Given this list of marker genes RBBP7, FYN, CTBP2, PSMD6, TWIST2, PSMA4, OST4, RBBP4, TMEM258, ARHGAP32, MOGS, MIR9-1, SUZ12, SNAI1, TCF3, PSMA6, PSMD2, ACTC1, KMT5A, H3-3A, SNAI2, ZBTB33, SP1, FOXA2, HDAC1, SIRT1, SMARCA4, ACTB, PSMD13, SPCS3, TLE1, H2AC20, H2BC1, MAPK1, OSTC, RB1, PSMB4, RPS27A (NCBI Gene Id 6233), PSMC2, PSMB1, HDAC2, MYCN, PSMB5, CBLL1, ACTA1, GANAB, PSMA7, EPS15, H2AC6 (H2A clustered histone 6), TGIF2, PSMD8, PSMD14, ADRM1, POMT1, MIR9-2, ACTA2, SEM1, H2BC3, PCSK6, PSMA2, H2AC4, SPCS1, CTNNB1, ZNF217, FURIN, H4C1, PSMD7, TFAP2A, CTSL, H2BC12L, H2AC18 (NCBI Gene Id 8337), UBB, SEC11A, TCF12, PSMB7 (proteasome 20S subunit beta 7), ZEB2, PSMA1, PSMD3, CTSS, ZEB1, AGO4, PRKCSH, MAPK3, TNRC6A, H2BC26, ANK3, DNTTIP1, SRC, KDM1A, H2BC5, H2BC17, AGO2, CSNK2A1, DDOST, ACTG2, PSMB2, PSMC6, H2BC13, MYC, AGO3, H2AZ2 (NCBI Gene Id 94239), SEC11C, VCL, PSMB6, H2AJ, CSNK2B, CANX, H2AC14, TWIST1, TNRC6B (NCBI Gene Id 23112), PSMC4, PIP5K1C, PSMC3, MTBP, CTNNA1, STT3A, H2BC4, MPHOSPH8, H2BC14 (H2B clustered histone 14), WT1, STRAP, H2BC15, CSNK2A2, H3C1, H2BC11, H2BC21, RPN1, UBC, H2AX, FOXQ1, DAD1, MCRIP1, EZH2, FOXJ2, FOXP2, CTNND1, H2BC9, PKM, H3C15, PSMC5, PSMA3, ACTG1 (NCBI Gene Id 71), PSMA5, CTBP1, CDH1 (cadherin 1), UCA1, MIR9-3, KLF4, CSNK2A3, PCSK7, ARID1A, PSMC1 (proteasome 26S subunit, ATPase 1), MIR10B, RPN2, UBA52, PSMB3, JUP, MOV10, PSMD12, BANP, PSMD11, H2AB1, KLF9, TNRC6C, AGO1, CTSB, DNM2, ZMYM2, POMT2 (protein O-mannosyltransferase 2), H2AC7, RACK1, MDM2, EED, PSMD1, H2BC12, SPCS2 (NCBI Gene Id 9789), here is a description of the gene set: <p>CDH1 (also known as E-cadherin, epithelial cadherin, Cadherin-1, CADH1, or uvomorulin) is a single-membrane-spanning protein with a conserved cytoplasmic domain and five extracellular cadherin domains separated by interdomain Ca2+ binding sites. Two CDH1 molecules expressed on basolateral membranes of neighboring cells form a homotypic trans-homodimer, a central complex in adherens junctions of polarized epithelia. CDH1 is connected to the cytoskeleton via its interactions with catenins.</p><p>Loss-of-function missense mutations in CDH1 are an underlying cause of about 30% of cases of hereditary diffuse gastric cancer (HDGC), and they affect various points in CDH1 posttranslational processing, trafficking, and interaction with protein partners, and a polymorphism in CDH1 gene promoter has also been associated with increased gastric cancer risk. CDH1 is frequently downregulated in tumors of epithelial origin and is considered to be a tumor suppressor gene. Loss of CDH1 expression promotes epithelial-to-mesenchymal transition (EMT), implicated in tumor invasiveness. The early stage of EMT is thought to involve removal of CDH1 from the plasma membrane and proteolytic degradation, while the later stage/established EMT is thought to involve repression of CDH1 gene transcription.</p><p>This pathway depicts regulation of CDH1 gene expression at the level of transcription and translation, posttranslational processing and trafficking of CDH1, establishment of CDH1 complexes with catenins and homotypic dimers, and ubiquitin-mediated degradation of CDH1.</p> studied in species Homo sapiens part of: Regulation of Expression and Function of Type I Classical Cadherins Reactome Pathway: Regulation of CDH1 Expression and Function